Given this list of marker genes Mtrr, Mmab, Mmachc, here is a description of the gene set: This event has been computationally inferred from an event that has been demonstrated in another species.<p>The inference is based on the homology mapping from PANTHER. Briefly, reactions for which all involved PhysicalEntities (in input, output and catalyst) have a mapped orthologue/paralogue (for complexes at least 75% of components must have a mapping) are inferred to the other species. electronically inferred by orthology from the curated human pathway studied in species Mus musculus part of: Cobalamin (Cbl, vitamin B12) transport and metabolism Reactome Pathway: Cobalamin (Cbl) metabolism